The following is a description of a gene set: Mitochondrial complex I assembly model OXPHOS system studied in species Homo sapiens Human Gene Set: WP_MITOCHONDRIAL_COMPLEX_I_ASSEMBLY_MODEL_OXPHOS_SYSTEM, and this is the list of marker genes: NDUFA5, NDUFA7, NDUFB7, NDUFA8, NDUFAF7, NDUFS4, NDUFB11, NDUFAF6, ECSIT, NDUFV1, NDUFC2, NDUFA1, TMEM186, NDUFA13, NDUFA6, ACAD9, MT-ND4L, DMAC2, NDUFAF1, NDUFS2, NDUFB2, NDUFS3 (NCBI Gene Id 4722), NDUFS5, DMAC1, NDUFV3 (NADH:ubiquinone oxidoreductase subunit V3), NDUFB8, NDUFB3, NDUFA12, FOXRED1, NDUFS1, NDUFB1, NDUFB6, NDUFB10, NDUFAB1, NDUFAF2, COA1, NDUFA2, NDUFAF4, NDUFA10, NDUFB5, NDUFB4, NDUFAF3, MT-ND6, MT-ND5, NDUFC1, TMEM70, NUBPL, MT-ND4, TMEM126B, NDUFA3, NDUFV2, NDUFB9, MT-ND2, NDUFS6, MT-ND1, TIMMDC1